Given this list of marker genes PPP2R3C, PAH, KIF7, DVL1, TWIST1, CANT1, FGFR2, here is a description of the gene set: A partial duplication, depending on severity leading to a broad or bifid appearance, affecting one or more of the distal phalanges of the hand. As opposed to a complete duplication there is still a variable degree of fusion between the duplicated bones. Human Gene Set: HP_PARTIAL_DUPLICATION_OF_THE_DISTAL_PHALANGES_OF_THE_HAND Partial duplication of the distal phalanges of the hand studied in species Homo sapiens